Given this list of marker genes BTG1, TFPI, SYN1, AK4, NBN, SLC11A2, CDK2, CSF2RB, S100A2, MTMR11, PLXNA3, MLH1, ACO1, MAP3K14, P4HA1, PRSS8, CEP170B, GADD45G, CYP4A11, SYT1, SLC39A8, CD86, NFKB1, CHST2, CHI3L1, PPBPP2, BASP1, FGFR2, KRT16, MARCKSL1, ZBTB17, LILRB4, B4GALT1, ACKR1, IL3 (NCBI Gene Id 3562), DMXL2, SELL, RBPMS, LY75, UGCG, CTSL, LDHA, CCL4, TRAF5, ALDH1B1, FXR2, MYB, GSDME (NCBI Gene Id 1687), CST7, CFLAR, COQ9, TRAF1, ADAM19, CAMK2B, CDX2, ELK1, PHACTR1, DYNLT3, SYCP1, IRF7, PDZK1, KRT86 (keratin 86), EZH2, CASP7, ACRV1, IVNS1ABP, VEGFA, RHOQ, H6PD (hexose-6-phosphate dehydrogenase/glucose 1-dehydrogenase), BRCA1, BCL2A1, H1-0, IFI6, MAOA, TRDMT1, MSC, CCL3 (NCBI Gene Id 6348), VCAM1, TNFAIP3 (TNF alpha induced protein 3), IL1RN, FCGR2A, ADM, H2BC21, MYOG, SKIC8, IFT140, MT1F, SMYD5, SLC2A3, CACYBP, GPR3, ZFP36L1, ALDH1A2, CYP4B1, GPR183, ZNF84, GPR39, PLCL1, USH2A, RBMS3, KCNA3, MT1G, CYB5R3 (NCBI Gene Id 1727), ENO2, NUDT3, DUSP5, PTGER2, PPP3CC, MSMB, AP3M2, HBEGF, PLK1 (polo like kinase 1), RPS6KB1, CXCL8, EXOC6B, LAMP3, RCAN1, AKR1B1, MGLL, PAEP (progestagen associated endometrial protein), HTR7, TRPC6, BID, PLK3, DIPK1A, EPB41L3, TIMP1, KDM5C, IRF4, WNT2B, UGP2, NFKBIA, CACNB1, GM2A, CNN3, DUXAP10 (NCBI Gene Id 503639), G0S2, BTG3, NTSR2, NR1H3 (NCBI Gene Id 113429), IL15RA, KIF2A, NPAS2, RHCE, SRPX, ACOX1, PLIN2, RBBP7, PKLR, FSCN1, TULP1, VRK2, ITGB3, QSOX1, ANKRD46, IER3, PNRC1, CD200, AFF2, GADD45B, ETS2, ATP2B2, RDH11, GCDH, MT1B, NEDD8, STX11, MUC1, AQP9, NINJ1, MMP1, PCDHB11, PRKAR2B, PLXNC1, PCK1, EIF2S1, MX1, OLR1, MISP, KLF6, BAAT, GSE1, CADM1, HOPX, ATP6AP1, RNF19B, RAB11FIP5, TYMP, RGS16, NLRP3, AHR, MORC3, DDIT4, MACIR, PRELP, NMI, ISG15 (NCBI Gene Id 9636), MT2A, MMP9, here is a description of the gene set: Human Gene Set: GSE360_L_DONOVANI_VS_B_MALAYI_HIGH_DOSE_DC_UP Monocyte-derived dendritic cells (DC) and macrophages (MΦ) generated in vitro from the same individual blood donors were exposed to five different pathogens, and gene expression profiles were assessed by microarray analysis. Responses to Mycobacterium tuberculosis and to phylogenetically distinct protozoan (Leishmania major, L. donovani, Toxoplasma gondii) and helminth (Brugia malayi) parasites were examined, each of which produces chronic infections in humans yet vary considerably in the nature of the immune responses they trigger. studied in species Homo sapiens from publication Chaussabel D, Semnani RT, McDowell MA, Sacks D, Sher A, Nutman TB (PMID 12663451) Genes up-regulated in comparison of dendritic cells (DC) exposed to L. donovani versus DCs exposed to 50 worm/well B. malayi.